Given this list of marker genes Cd3e, Foxp3, Runx1, Lilrb4a, Cblb, Cd86, Nr5a2, Lilrb4b, Itch, Phlpp1, here is a description of the gene set: Any process contributing to lymphocyte anergy, a state of functional inactivation. Mouse Gene Set: GOBP_LYMPHOCYTE_ANERGY species: Mus musculus